Given this list of marker genes COL6A1, MTNR1A, USP32, HTR4, GDNF, FLNC, FEM1B, GCG, PRKCG, HOXA4, NEDD8, REG3G, ZKSCAN5 (NCBI Gene Id 23660), CDC20, NKX1-2, VRK3, SERPINC1, EEF1G, LY9, HCFC1, NPY1R, HOXC4, CP, ECM1, CCL1, NEUROD4 (NCBI Gene Id 58158), DBP, STRBP, BMP8B, WDFY3, MTOR, ST3GAL5, RAN, TAOK3, RAD52, CSTF2 (NCBI Gene Id 1478), GSPT1, HES3, NMB, PSMB7, SEZ6, LTB, MYL11, ASIP (NCBI Gene Id 434), PTPRR, MPP1, MASP1, FABP5, HSPA8, ADRA2A, NREP, NR2F1, PRKDC (protein kinase, DNA-activated, catalytic subunit), BGLAP, PAPOLA, UIMC1, ACTC1, IFNA1, RET, TRIM10, MYL4, UFD1, FGF11, HLA-DMA, GLI3, MAP3K7, INMT, GPX3, MAP2K5, here is a description of the gene set: studied in species Mus musculus Ageing of the brain leads to impairments in cognitive and motor skills, and is the major risk factor for several common neurological disorders such as Alzheimer disease (AD) and Parkinson disease (PD). Recent studies suggest that normal brain ageing is associated with subtle morphological and functional alterations in specific neuronal circuits, as opposed to large-scale neuronal loss. In fact, ageing of the central nervous system in diverse mammalian species shares many features, such as atrophy of pyramidal neurons, synaptic atrophy, decrease of striatal dopamine receptors, accumulation of fluorescent pigments, cytoskeletal abnormalities, and reactive astrocytes and microglia. To provide the first global analysis of brain ageing at the molecular level, we used oligonucleotide arrays representing genes to determine the gene-expression profile of the ageing neocortex and cerebellum in mice. Ageing resulted in a gene-expression profile indicative of an inflammatory response, oxidative stress and reduced neurotrophic support in both brain regions. At the transcriptional level, brain ageing in mice displays parallels with human neurodegenerative disorders. Caloric restriction, which retards the ageing process in mammals, selectively attenuated the age-associated induction of genes encoding inflammatory and stress responses. from publication Lee CK, Weindruch R, Prolla TA (PMID 10888876) Human Gene Set: LEE_AGING_NEOCORTEX_DN Downregulated in the neocortex of aged adult mice (30-month) vs young adult (5-month)